Given this list of marker genes SLC2A9, here is a description of the gene set: part of: SLC transporter disorders Reactome Pathway: Defective SLC2A9 causes hypouricemia renal 2 (RHUC2) species: Homo sapiens The human SLC2A9 gene encodes the class II facilitative glucose transporter 9 (GLUT9). SLC2A9 is expressed mainly in kidney (proximal tubules of epithelial cells) and liver. SLC2A9 is a bona fide urate transporter (uric acid), but also the uptake of fructose (Fru) and glucose (Glc) at a low rate. Uric acid is the end product of purine metabolism in humans and great apes. Defects in SLC2A9 can cause renal hypouricemia 2 (RHUC2), a common inherited disorder characterised by impaired renal urate reabsorption and resultant low serum urate levels. Some patients present with severe complications, such as exercise-induced acute kidney injury (EIAKI) and nephrolithiasis (Esparza Martin & Garcia Nieto 2011, Sebesta 2012, Shen et al. 2014).